The following is a description of a gene set: species: Homo sapiens Human Gene Set: GOBP_RESPONSE_TO_OXYGEN_GLUCOSE_DEPRIVATION Any process that results in a change in state or activity of a cell or an organism (in terms of movement, secretion, enzyme production, gene expression, etc.) as a result of the deprivation of oxygen and glucose., and this is the list of marker genes: MAP1LC3A, INHBA (inhibin subunit beta A), BNIP2, DRAM1, ZEB2, PARP2 (poly(ADP-ribose) polymerase 2), BNIP1 (NCBI Gene Id 662), SOX2, NPPC, BNIP3, BECN1